Given this list of marker genes KCNMB2, PDE10A, IRAG1, KCNMB3, PDE1B, PDE2A, PDE9A, KCNMB1, PDE1A, PDE5A, PDE11A, PRKG2, KCNMB4, KCNMA1, ITPR1, PRKG1, here is a description of the gene set: Reactome Pathway: cGMP effects part of: Nitric oxide stimulates guanylate cyclase species: Homo sapiens Cyclic guanosine monophosphate (cGMP) is an important secondary messenger synthesized by guanylate cyclases. cGMP has effects on phosphodiesterases (PDE), ion-gated channels, and the cGMP-dependent protein kinases (cGK, Protein Kinase G or PKG). It is involved in regulation of several physiological functions including vasodilation, platelet aggregation and neurotransmission. Elevation of intracellular cGMP activates PKG which regulates several intracellular molecules and pathways including the vasodilator-stimulated phosphoprotein (VASP) and the ERK pathway. cGMP mediates nitric oxide (NO)-induced vascular smooth muscle relaxation. Phosphodiesterase 5 (PDE5) hydrolyzes cGMP; the PDE5 inhibitor sildenafil (Viagra) increases intracellular cGMP and thereby can be used as a treatment for erectile dysfunction. The role of the cGMP and PKG in platelet activation was controversial as increases in platelet cGMP levels were observed in response to both platelet agonists (thrombin, ADP or collagen) and inhibitors (NO donors such as sodium nitroprusside), but it is currently accepted that PKG inhibits platelet activation. Consistent with this, nitric oxide (NO) donors that inhibit platelet activation enhance intracellular cGMP. cGMP also plays an important stimulatory role in GPIb-IX-mediated platelet activation. Platelet responses to cGMP have been proposed to be biphasic, consisting of an early stimulatory response that promotes platelet activation followed by a delayed platelet inhibition that serves to limit the size of platelet aggregates.